The following is a description of a gene set: TRAF3-dependent IRF activation pathway studied in species Homo sapiens Human Gene Set: REACTOME_TRAF3_DEPENDENT_IRF_ACTIVATION_PATHWAY, and this is the list of marker genes: TRIM25, SIKE1, IKBKE, RNF135, EP300, IFNB1, IFIH1, TRAF3, TBK1, IRF7, MAVS (NCBI Gene Id 78993), IRF3, CREBBP, RIGI, TRIM4